Given this list of marker genes HRAS, SDHB, SDHC, NRAS, PIK3CA, SRGAP1, PRKAR1A, SEC23B, PDE11A, USF3, HABP2, AKT1, PTEN, SDHD, KLLN, MINPP1, FOXE1, here is a description of the gene set: studied in species Homo sapiens The presence of an follicular adenocarcinoma of the thyroid gland. Human Gene Set: HP_FOLLICULAR_THYROID_CARCINOMA Follicular thyroid carcinoma